Given this list of marker genes Pik3cb, Sema6a, Adamts9, Thbs1 (NCBI Gene Id 21825), S2bpcox16, Sh2b3, Synj2bp, Alox5, E2f2, Klf2, Creb3l1, Stard13, Epn1, Epn2, Flt1, Zfp354c, here is a description of the gene set: Any process that stops, prevents or reduces the frequency, rate or extent of sprouting angiogenesis. Mouse Gene Set: GOBP_NEGATIVE_REGULATION_OF_SPROUTING_ANGIOGENESIS studied in species Mus musculus